The following is a description of a gene set: Cytosolic sulfonation of small molecules Human Gene Set: REACTOME_CYTOSOLIC_SULFONATION_OF_SMALL_MOLECULES species: Homo sapiens, and this is the list of marker genes: SULT2B1, SULT4A1, BPNT1, SULT2A1, SULT1A1, PAPSS2, SLC26A1, SULT1A4, SLC35B3, SLC26A2, SULT6B1, SULT1A2, PODXL2, SULT1C4, SULT1B1, ABHD14B, TPST1, TPST2, BPNT2, PAPSS1, SULT1C2, SULT1A3, SLC35B2, SULT1E1